Given this list of marker genes Abca8b (NCBI Gene Id 27404), Abca5, Abca7, Abcc2, Abca1, Abcc5 (NCBI Gene Id 78340), Abcg8, Abca9, Abcc4, Abcd4, Atp13a3, Abca6, Abcd1, Abca2, Ralbp1, Abcb10, Abcc9, Abca12, Abcb11, Atp13a2, Abcb7, Abca8a, Abcc6, Abcg1, Abcg5, Abcd2, Tap2, Abcc3, Abcc12, Abcc10, Abca13, Abcb4, Abcb8, Abca3, Abcb5 (NCBI Gene Id 77706), Abcc1, Abcb1a, Abcb1b, Abca4, Abcb6, Cftr, Abcd3, Abcb9, Abca17, Abcg4, Abcg2, Abcg3, Tap1 (NCBI Gene Id 21354), here is a description of the gene set: Primary active transporter characterized by two nucleotide-binding domains and two transmembrane domains. Uses the energy generated from ATP hydrolysis to drive the transport of a substance across a membrane. Mouse Gene Set: GOMF_ABC_TYPE_TRANSPORTER_ACTIVITY studied in species Mus musculus